The following is a description of a gene set: A protein complex which is capable of protein kinase activity. Mouse Gene Set: GOCC_PROTEIN_KINASE_COMPLEX studied in species Mus musculus, and this is the list of marker genes: Prkag2, Nek10, Ccnb1, Cdk7, Prkaa2, Pcna, Prkab2, Erc1, Cdkn2d, Ccng2, Cdk14, Prkar2a, Prkag3, Rb1, Smcr8, Ccne1, Gtf2h2, Ccno, Gtf2h5 (general transcription factor IIH, polypeptide 5), Phkb, Phkg2, Cab39, Prkdc, Ccnj, Cdk5r1, Bccip, Chuk, Ccne2, Phka2, Cdk3, Ccnb2, Pard6a, Prkaca, Insr, Tgfbr2, Ccnq, Cks2, Mtor, Prkaa1, Cdk8, Phka1, Pycard, Ceacam2, Cnppd1, Stradb, Gtf2h4, Cdk2, Ccnd3, Phkg1, Insrr, Dbf4, Med13, Ccnc, Cdk16, Ikbkb, Cks1brt, Atg13, Las1l, Acvr1, Ccna2, Cdk6, Cdkn1a, Tgfbr1, Ceacam1, Csnk2b, Acvr2a, Prkar1b, Pard3, Map3k5, Prkci, Ccny, Mlst8, Sesn2, Uvrag, Ccnjl, Prkab1, Cdk5r2, Ikbkg, Xrcc5, Cdk12, Stk11, Ccna1, Ercc3, Cdk4, Wdr41, Ccnb1-ps, Irs1, Cks1b, Atg101, Trim40, Cdk13, Csnk2a2, Prkx, Rictor (NCBI Gene Id 78757), Brd4, Rb1cc1, Ccnt1, Prkag1, Ccng1, Dapk1, C9orf72, Ccnd2, Tex24, Xrcc6, Gtf2f2, Psmc5, Gtf2h3, Ccnt2, Ccnh, Acvr1b, Ccnf, Cdk1, Acvr1c, Akap14, Prkar2b (protein kinase, cAMP dependent regulatory, type II beta), Gtf2h1, Prkacb, Ercc2, Ulk1, Ccnl2, Mnat1, Ccnk, Ccnd1, Snw1, Tbc1d5, Strada, Cdk10, Igf1r, Ccnb3, Acvr2b, Med12, Mapkap1, Ccnl1, Prkar1a, Cdk5, Cdk11b, Ccni, Zbtb7a, Cdk9, Csnk2a1